The following is a description of a gene set: studied in species Homo sapiens Any process that modulates the frequency, rate or extent of the addition of SUMO groups to a protein. Human Gene Set: GOBP_REGULATION_OF_PROTEIN_SUMOYLATION, and this is the list of marker genes: GNL3, HMG20B, FSCB, PIAS1, UBA2, CDKN2A, HMG20A (high mobility group 20A), EGR1, SAE1, MUL1, HDAC4, TOLLIP, PARK7, RWDD3, MAGEA2B, ARNT, GNL3L (G protein nucleolar 3 like), RASD2, CAPN3, PIAS4, CTNNB1, MAGEA2, RELA, PIAS3